The following is a description of a gene set: from publication Xie X, Lu J, Kulbokas EJ, Golub TR, Mootha V, Lindblad-Toh K, Lander ES, Kellis M (PMID 15735639) species: Homo sapiens Human Gene Set: TGGNNNNNNKCCAR_UNKNOWN Comprehensive identification of all functional elements encoded in the human genome is a fundamental need in biomedical research. Here, we present a comparative analysis of the human, mouse, rat and dog genomes to create a systematic catalogue of common regulatory motifs in promoters and 3' untranslated regions (3' UTRs). The promoter analysis yields 174 candidate motifs, including most previously known transcription-factor binding sites and 105 new motifs. The 3'-UTR analysis yields 106 motifs likely to be involved in post-transcriptional regulation. Nearly one-half are associated with microRNAs (miRNAs), leading to the discovery of many new miRNA genes and their likely target genes. Our results suggest that previous estimates of the number of human miRNA genes were low, and that miRNAs regulate at least 20% of human genes. The overall results provide a systematic view of gene regulation in the human, which will be refined as additional mammalian genomes become available. Genes having at least one occurrence of the highly conserved motif M27 TGGNNNNNNKCCAR in the regions spanning 4 kb centered on their transcription starting sites. The motif does not match any known transcription factor binding site., and this is the list of marker genes: ALDH3B1, DNMT3A, GAL3ST1, MTCH2, ITIH6, VAMP1 (vesicle associated membrane protein 1), SIPA1, TFR2, TRIM46, FAM118B, FOXI2, CUEDC1, OVOL1, RNF213, FAP, LMOD1, STARD13, MOV10, LRRN4CL, HHATL, CHST9, SHISA6, UBE2R2, CREBL2 (NCBI Gene Id 1389), ORAI3, LINC00474, CHP1, NR2C2, PIK3R3, MAP3K14, SPINK4, NR1H3, CIPC, DDR2, CYTH3, PRELID1, TBCB, ESRP2, LYPLA2, EFNB1, CARMIL3, VCL, MT-ND5, MID1, HEY1, GOT1, WNT5A, SH3TC1, JPH3 (NCBI Gene Id 57338), CACNB1, COLQ, NLN, MGAT4A, GDPD2, TMEM255A, PDLIM7, MYOG (NCBI Gene Id 4656), SH2D4A, TMOD4, LRRTM1, C1QTNF1, LINC00299, PRKRA (protein activator of interferon induced protein kinase EIF2AK2), OARD1, SLC4A1, PAG1, TRAF4, EI24, LRRC59, NFATC1, STAT5A, TP53, NUDCD1, SALL1, SOX15, USP54, NECAB3, KLK13, RERE, SLCO2A1, FXYD1, WDR44, WDPCP, RGN, XPR1, DIO2, JPH4, RTBDN, CDH5, VIM, MIR600HG, CKMT1B, MEF2C, SALL4, SETD7, HOXA3, MPP2, PCDHGC3, SEMA3C, CFI, GPRASP1, PHF12, IKZF2, SETD3, MYCN, PDK2, SLC3A1, SGCD, KANK2, LIX1L, SDC1, ZNF462, PRRC2C, TGIF2, ELMO1, LINC01565, BLCAP, DOK7, CBFA2T2, MYL11, ASS1, LOX, SLC2A4, WBP1L, OSBPL9, GNB1L, HBEGF, RIN2, PLXNA3, RPL23A, SLC22A17, ARL4C, HDLBP, ARFIP2, FOXN1, TIMM10B, ANKRD39, TSC22D4, TCN2, RASL11B, RBPJ (NCBI Gene Id 51580), NPPA, RTN1 (reticulon 1), IGFBP5 (NCBI Gene Id 3488), SNCAIP, PCOLCE, NNAT, ARHGEF5, CAMKV, ARHGAP8, FSCN2, PRSS36, HOXA6, KCNG3, GSKIP, ACTA1, NRK, SLC25A24, STAT5B, RAP2C, UBE2H, CTHRC1, FGL1, EIF4G2, HBP1, EYA3, EMID1, ATAD3C, EXD1, SCNN1A, EVA1C, SCD, PCBP4, FAM53B, PLAT, CRYAB, EPPIN (epididymal peptidase inhibitor), ZNF189 (NCBI Gene Id 7743), SFRP2, GCM1, PNRC1, RAB24, ITM2B, KIF1B, PTGDS, ZFPM2, ZNF664, KCNN3, NCKAP5, KREMEN2, ZHX2, CYP1A2, IL6, ATP2A2, CCDC177, ST6GALNAC5, SGMS1, CTNNA3, DAB2IP, ALDOA, SCN4B, FGF11, SPIB (NCBI Gene Id 6689), SEC11C, CDK2AP1 (cyclin dependent kinase 2 associated protein 1), MLLT10, EPHB6, STARD3, PTGFR, TTC19, REM2, CCN1, SMAD6, TIMP4, TMEM178A, TOX2, SYNPO2L, SFTPC, CCDC9B, PPME1, EIF2A, KERA, PODN (NCBI Gene Id 127435), MAGEL2, F9, C16orf89, IER5L, PELO, PLCXD2, VWA7, RUFY1, FADS3, IPO7, COA3, RORC, KMT2E, CSRNP1, HIF3A, RBM14, PDZRN4, DENND5A, NFIA, ITGA1, TMEM131L, ADM2, MACROD1, SYT12, ASIC3, VWA1, PRKAR2A, RNF186, GPR119, LMLN, ADGRG6, ISYNA1, WRAP53, NFIB, KCNH2, C17orf58 (chromosome 17 open reading frame 58), RALYL, PCK1, PLCD4, NLGN3, SPRY1, MLLT3, MRPL50, NTNG2, SULT1A1, CA7, RAB34, GTPBP2, SWAP70, CAMP, FOXP2, SCGB1A1, POLR2I, MAPK3, ANKRD17, B3GALT2, SLC22A8, ADD3, CS, SMAD7, FERD3L, CAVIN1, PIK3C3, EHD4, ROR1, HPN, ZFHX3, ARHGEF2, DDHD1, KRTCAP2, SLC38A3, MSRB3, VEGFA, CCN5, KCNN4, ARHGEF19, GPRASP2, MTF2, IRAG1, MT-ND4, HMGA2, CAVIN2, MTSS1, KANK1, ADAMTSL2, TANK, ATP1B1, NXPH1, PADI1, GPC4, ADAMTS7, PDGFRB, PRDM13, GDPD3, COL6A3, LINC00649, CLCN3, PPTC7, STON2, KRT4, CBL, YPEL3, TNFSF15, MAP3K5, KRT17 (NCBI Gene Id 5103), FCGBP (NCBI Gene Id 8857), VIP, LY75, KIAA0040, RBBP7, SULT1A2, DUSP14, MT-ND4L, RTL10, FAM53C, GNAT1, BRD4, NEK1, LIPT2-AS1, EXTL3, MTMR4, SRCIN1, PPARGC1A, HOXA10, GABRP, RNF43, S100A8, CAV3, TPPP3, STARD8, SPTB, LRRC17, PBX2, SPP2, BHLHE40, CHST5, LAMA5, PRR15, ANXA3, GRHL3, PGF, GCC1, NEFM (NCBI Gene Id 4741), SPMIP5, FARP1, CYRIA, GPRC5C, LINC00314, NFKBIA, SERP1, HOXB6, MARCHF5, EDA, CASQ1, SYT9, CHRM1, ADAM23, RETNLB, SLC31A2, EBF2, SGTB, GNG12, HOXA9, LSMEM2, NEUROD2, ST13P4, KLF14, NFYA, TINAGL1, DGKD, PLA2G3, PTHLH, CGB2, MPL, HDX, CNTD1, OSBPL7, ARL13B, SLC22A1, STXBP6, APLN, WFDC6, SCRT2, DDIT4L, PLXNB1, CPEB3 (cytoplasmic polyadenylation element binding protein 3), PDGFB, CBX2, MLF2, MORC4, SLC39A4, H1-10, RPE65 (NCBI Gene Id 6121), TMEM182 (transmembrane protein 182), IQCG, NR2F1, DUSP3, AQP3, CCDC92, PPARA (peroxisome proliferator activated receptor alpha), RBMX, IGSF1, HFM1, VASN, TMTC2, CREB5, FHL1, ATP10B, GLS (glutaminase), SBSPON, RALGPS2, CAMK1, NRXN3